The following is a description of a gene set: species: Homo sapiens Genes up-regulated in comparison of control dendritic cells (DC) at 6 h versus those stimulated with Gardiquimod (TLR7 agonist) at 6 h. Human Gene Set: GSE17721_CTRL_VS_GARDIQUIMOD_6H_BMDC_UP mouse primary BMDCs were stimulated with tlr ligands and gene expression changes were profiled on Affymetrix arrays from publication Amit I, Garber M, Chevrier N, Leite AP, Donner Y, Eisenhaure T, Guttman M, Grenier JK, Li W, Zuk O, Schubert LA, Birditt B, Shay T, Goren A, Zhang X, Smith Z, Deering R, McDonald RC, Cabili M, Bernstein BE, Rinn JL, Meissner A, Root DE, Hacohen N, Regev A (PMID 19729616), and this is the list of marker genes: RPS3, WASF2, TMEM216, FUOM, IPPK, TSPAN14, LYST, ORMDL2, FABP7, IQSEC1, SGSH, CXCR5, PNPLA7, EVI5, CCNB2 (NCBI Gene Id 9133), CDK2, OR6A2, ZNF106, ERLIN1, DYNLT1, PPP3CA, IVD, SESN1, GUCA1A, CUEDC2, PTPN6, BRCC3, OCEL1, RPL30, PNPO, HAND1, DUSP7, DDIT3, BAIAP2, NCKIPSD, CENPE, GALT, HMGCL, ATG12, CHCHD6, POLA1, CDCA7L, CENPA, MRPL49, PLPP2 (NCBI Gene Id 8612), HAUS8, TRIM25, FLCN, GPX4, ITM2C, PBX2, RPS8, IER5L, TMEM179B, CPPED1, GDI2, SH3BP5L, TM9SF1, HAUS3, PPP1CC, SUPT5H, ACO1, MRPS24, KLRK1, GMPR, GLO1, KCNK2, LYSMD3, IQGAP3, DAP, YWHAH, HMBS, CDH23, FAM32A, ACOT13, AAGAB, PALM, NR1D2, ANKRD10 (NCBI Gene Id 55608), CNOT6L, SCEL, SRRM1, MAD1L1, MRC1, NDUFV3, SLC25A39, ABHD15, C1orf54, ARRB1, DCAF11, ACTR6, TPRA1, NDST1, MRPL28, COA6, RFC1, HABP4, PADI1, LMNB2, GALK2, RBM42, KIAA1143, IRAG2, SNX1, MSL3, HMGB2, MFSD6, NCOA1 (NCBI Gene Id 8648), OR2S2, SIPA1, ZNF703, FAM117A, LDLRAP1, RXRB, NUF2 (NCBI Gene Id 83540), SLC46A1, LPGAT1, ZNF124, MGST2, DCAF12, AKR7A2, CPT1A, LSP1, NDUFA10, TMEM43, PGD, LEPROT, HADH, TAF9, CLYBL, MYL12B, TTC4, FAM98C, SLC25A35, SYF2, DOK3, HNRNPUL1, MRPL44, STK10, DDIT4, HPCAL1, TTYH2, MYOZ1, NCOR1, NUDT7, TEC, MRPL47, TP53, MDH1, RGL2, PLA2G15, MMP19, F7, GOLM1, ARHGAP45, LIMK1, C1D, NUP35, XPR1, CATSPERG, ECH1, TECPR1, ICAM4, NAXE, TUBB2B, MCM7, SYNPO, CRADD, XPC, FRMD4B, RASSF5, DIP2B, RBM47, TXNDC5, HDAC6, ZNF277, SPATS2, DIPK1B, MARVELD2, PALS2 (NCBI Gene Id 55569), FRAT1, RGS19, COPZ2, HMGCS1, MBP, PARP3, FBXL12, ANKH, CDC25B, HLA-DMA, TMUB2, SKIC8, RASAL3, USP11, LYSMD2, MANBA, UFSP2, SNX15, PTPRO, XIST